The following is a description of a gene set: Human Gene Set: HOEK_NEUTROPHIL_2011_2012_TIV_ADULT_7DY_DN from publication Hoek KL, Samir P, Howard LM, Niu X, Prasad N, Galassie A, Liu Q, Allos TM, Floyd KA, Guo Y, Shyr Y, Levy SE, Joyce S, Edwards KM, Link AJ (PMID 25706537) Systems biology is an approach to comprehensively study complex interactions within a biological system. Most published systems vaccinology studies have utilized whole blood or peripheral blood mononuclear cells (PBMC) to monitor the immune response after vaccination. Because human blood is comprised of multiple hematopoietic cell types, the potential for masking responses of under-represented cell populations is increased when analyzing whole blood or PBMC. To investigate the contribution of individual cell types to the immune response after vaccination, we established a rapid and efficient method to purify human T and B cells, natural killer (NK) cells, myeloid dendritic cells (mDC), monocytes, and neutrophils from fresh venous blood. Purified cells were fractionated and processed in a single day. RNA-Seq and quantitative shotgun proteomics were performed to determine expression profiles for each cell type prior to and after inactivated seasonal influenza vaccination. Our results show that transcriptomic and proteomic profiles generated from purified immune cells differ significantly from PBMC. Differential expression analysis for each immune cell type also shows unique transcriptomic and proteomic expression profiles as well as changing biological networks at early time points after vaccination. This cell type-specific information provides a more comprehensive approach to monitor vaccine responses. Genes down-regulated in neutrophil 7d vs 0d in adults after exposure to 2011-2012 trivalent inactivated vaccine (A/California/7/09 (H1N1), A/Perth /16/2009 (H3N2), B/Brisbane/60/2008), time point 7D. Comment: Down-regulated DE RNA transcripts (down >= 1.5x) shared between both TIV-vaccinated donors studied in species Homo sapiens, and this is the list of marker genes: RSAD2, LILRA4, GBP5, IFT52, AP1M2, LY6E, OAS3, RTP4, IFI44, ISG15, OAS1, EPSTI1, APOBEC3D, BATF2, IFI6, H2BC11, GBP6, PPDPF (NCBI Gene Id 79144), SERPING1, APOL3 (apolipoprotein L3), NASP, ATF3, HEBP1, CMPK2, ETV7, IFITM3, NRIR, PNPT1, APEX2, IFI44L, LIMK1, SRXN1, OAS2, FRMD3, OSM, CCDC85B, NUP54, DIMT1, COA6, RILP